The following is a description of a gene set: species: Mus musculus Mouse Gene Set: GOBP_NEGATIVE_REGULATION_OF_ENDOTHELIAL_CELL_APOPTOTIC_PROCESS Any process that stops, prevents or reduces the frequency, rate or extent of endothelial cell apoptotic process., and this is the list of marker genes: Angpt1, Sema5a, Nfe2l2, Il10, Pak4, Gata2, Tnfaip3, Tert, Abl2, Ndnf, Cdh5, Fgf21, Pdpk1, Il13, Tnip2, Fga, Kdr, Krit1, Mapk7, Angptl4, Ramp2, Scg2, Itgb3, Fgb, Fgg, Serpine1, Id1, Tek, Il4, Gas6, Gata3, Icam1, Braf, Abl1